The following is a description of a gene set: Mouse Gene Set: MIR_7670_5P Genes predicted to be targets of miRBase v22 microRNA mmu_miR_7670_5p in miRDB v6.0 with MirTarget v4 prediction scores > 80 (high confidence targets). species: Mus musculus from publication Chen Y, Wang X (PMID 31504780), and this is the list of marker genes: Tmem167, Npy2r, Rims2, Ddx46, Iars2, Usp15, Mindy2, Foxn3 (NCBI Gene Id 71375), Wipf1, Taok1, Megf11, Opn3, Art3, Mapk9, Rc3h1, Cp, Zc3h14, Ybx3, Naaladl2, Ap1ar, Cntn1, Sass6, Dus4l, Ino80c, Ago2, Pik3cg, Rhoq, Aif1l, Kcnj16, Fpr3, Dach2, Rbm39, Papln, Pde7a, Stat6, Fpr2, Car5b, Med13l, Lysmd3, Cfap69, Cyth3, Pls3, Stam2, Rimklb, Nipa2, Rpa1, Ccdc179, Hdac9, Mctp1 (NCBI Gene Id 78771), Pggt1b, Cldn18, D430041D05Rik, Zfp760, Zdhhc15, Sypl2, Kdm7a, Lyset, Tyr, Cdc73, Kcnab1, Camk2d, Magi1, Clcc1, Evi5, Tgfa, Taf13, Esyt2, Glt8d2, Cntnap4, Oprk1, Gm12886, Cndp1, Rap1a, Dusp16, Fam216b, Tnrc6b, Cdk12, Chit1, Eny2, Pdha1, Matr3, Vstm2a, Glrb, Slc25a24, Tmem229a, Ninj2, Fut9, Wac, Fut4, Trpc5, Ahcyl2, Hccs, Apba1, Stxbp5, Dennd5b, Fam117b, Hdx, Jchain, Tyms, Pramel24, Tmem33, Zfp110, Tm9sf3, Cdh13, Rnf38, Rufy3, Zbtb33 (zinc finger and BTB domain containing 33), Hook3 (hook microtubule tethering protein 3), Psrc1 (NCBI Gene Id 99778), Map1a, 2700097O09Rik, Ngp, Hadh, Gpr174, Itpripl2, Smyd3, Ufl1, Zc3h12c, Spag6l, Prkaa1, Vipr2, Tbl1xr1, Ugt2b1, 9530068E07Rik, Chic1, Tpk1, Nalcn, Cwc27, Ptger2, Pramel5, Fem1b, Ralgapa1, Gpc4, Pik3ca, Pmel (NCBI Gene Id 20431), Zfp202, Usp31, Cxadr, H2-T5, Eya4, Bbx, Tmem47, Dach1, Tmx3, Rnft1, Gfra1, Tmed5, Pde12, Lrba, Kdm4c (NCBI Gene Id 76804), Slitrk1, Rmdn3 (regulator of microtubule dynamics 3), Piga, Arhgap15, Map3k2, Ang6, Il2, Nup54, Lin28a, Nrsn1, Thsd7a, Memo1, Eml1, Fam120c, Gpr158, Ddc, Elmo1, Grm8, Btc (NCBI Gene Id 12223, betacellulin, epidermal growth factor family member), Tfec, Toe1, Gpr137c, Ccdc85a, Mapk8, Zmym2, Zfp512, Rps6kb1, Gask1b, Ercc6l2, Nr2f2, Mecom, Med23, Gdpd1, Taf3